The following is a description of a gene set: Any process that modulates the frequency, rate or extent of natural killer cell differentiation. studied in species Homo sapiens Human Gene Set: GOBP_REGULATION_OF_NATURAL_KILLER_CELL_DIFFERENTIATION, and this is the list of marker genes: IL21, PGLYRP1, ZBTB1, PGLYRP3, PGLYRP2, STAT5A, GAS6, IL15, AXL, RASGRP1, TOX, STAT5B, PRDM1, ZNF683, IL15RA (NCBI Gene Id 3601)